Given this list of marker genes ABCC2, here is a description of the gene set: studied in species Homo sapiens Canalicular multispecific organic anion transporter 1 (ABCC2 aka multidrug resistance-associated protein 2, MRP2), in addition to transporting many organic anions, mediates the ATP-dependent transport of glutathione and glucuronate conjugates from hepatocytes into bile. ABCC2 transports with high affinity and efficiency mono- and di-glucuronated bilirubin into bile. Bilirubin, the end product of heme breakdown, is an important constituent of bile and is responsible for its characteristic colour. Defects in ABCC2 can cause Dubin-Johnson syndrome (DJS; MIM:237500), an autosomal recessive disorder characterised by conjugated hyperbilirubinemia (Dubin & Johnson 1954, Keppler 2014, Erlinger et al. 2014). part of: ABC transporter disorders Reactome Pathway: Defective ABCC2 causes DJS